Given this list of marker genes Clasp1, Rab8a, Yipf5, Arhgap21, Golga5, Gcc2, Gbf1, Csnk1a1, Rbsn, Camsap3, Atp8b4, Vti1b, Bag5, Dnm2, Yipf4, Fam174b, Optn, Bet1 (Bet1 golgi vesicular membrane trafficking protein), Trappc11, Bhlha15, Rab2b, Vps13b, Tmed11, Tmed2, Arhgef7, Cdk1, Tmed10, Pdcd10, Sec16b, Hace1, Cog5, Armh3, Rab2a, Stk25, Dync2h1, Yipf7, Plekhm2, Lrrk2, Vps51, Rab33b, Arl1, Rab1b, Prkd1, Trip11, Tmed7, Nsfl1c, Ehd3, Tango2, Gorasp2, Cog6, Atp8b2, Surf4, Gorasp1, Cdc42, Clasp2, Pi4k2a, Cltc, Coro7, Stx18, Cog2, Vamp4, Cog4, Trappc8, Blzf1, Golga2, Golph3, Kifc3 (kinesin family member C3), Htt (huntingtin), Stx17, Ap5z1, Mapk3, Tbc1d20, Sec22b, Cit, Tmed4, Ptk2b, Atl3 (NCBI Gene Id 77020), Sptbn5, Cog7, Nploc4, Uso1, Pde4dip, Tmed9, Pi4k2b, Stx5a, Sec16a, Tmed3, Map2k1, Rab30, Rab1a (NCBI Gene Id 19324), Vmp1, Rab6b, Plk3, Tjap1, Fbxw8 (F-box and WD-40 domain protein 8), Dym, Camsap2, Lysmd3, Atp8b1, Trappc12, Cog8, Ywhaz (tyrosine 3-monooxygenase/tryptophan 5-monooxygenase activation protein, zeta polypeptide), Zw10, Myo18a, Ubxn2a, Usp6nl, Hook1, Rab43, Syne1, Atl2, Ubxn2b, Vrk1, Golph3l, Prmt5, Cul7, Huwe1, Tmed6, Mapk1, Cog3, Gak (NCBI Gene Id 231580), Garin4, Fhdc1, Naglu, Lman1, Rab29, Arfgef1, Hikeshi, Obsl1, Csnk1d, Tmed1, Akap9 (A kinase anchor protein 9), Vti1a, Tmed5, Atp8b5, Vcpip1 (valosin containing protein (p97)/p47 complex interacting protein 1), Map2k2, Atp8b3, Cog1, here is a description of the gene set: A process that is carried out at the cellular level which results in the assembly, arrangement of constituent parts, or disassembly of the Golgi apparatus. studied in species Mus musculus Mouse Gene Set: GOBP_GOLGI_ORGANIZATION